The following is a description of a gene set: species: Homo sapiens Autism Autism is a neurodevelopmental disorder characterized by impaired social interaction and communication, and by restricted and repetitive behavior. Autism begins in childhood. It is marked by the presence of markedly abnormal or impaired development in social interaction and communication and a markedly restricted repertoire of activity and interest. Manifestations of the disorder vary greatly depending on the developmental level and chronological age of the individual (DSM-IV). Human Gene Set: HP_AUTISM, and this is the list of marker genes: EEF1A2, DPAGT1, CNKSR2, OCA2, FTCD, TUBG1, BBS1, DPYD, RERE, LIMK1, ATP6V1A, KCNAB2, ANKRD11, WDPCP, SNORD115-1, GABRA2, STS, GABBR2, SUPT16H, DYRK1A, CACNA1A, MAN1B1, EHMT1, BBS9, HESX1, ARL6, DNAJC30, BBIP1, SNORD116-1, CNTNAP2, TAF4, MED12, BUD23, DPYS, BBS4 (Bardet-Biedl syndrome 4), GP1BB, ADNP, ALDH5A1, GABRD, LHX1, TBCK, PWRN1, PDE4D, BBS2, PDPN, RFC2, DNM1, ATRX, HECTD4, SLC13A5, CYFIP2, MAGEL2, EIF4H, OTX2, CEP19, WWOX, NTRK2, GAMT, TTC8, SPEN, ZBTB20, REV3L, GNB1, PTCHD1, EIF4A2, METTL27, SCLT1, GABRA5, ALG14, MKRN3, ATP1A2, AP3B2, KLLN, CYP27A1, NHS (NHS actin remodeling regulator), SEC24C, TAF6, SCN1A, DOCK7, NUS1, ABCB7, NIPA2, SOX3, UFD1, ELN, SETD2, ASXL3, BRD4 (NCBI Gene Id 90616), GTF2IRD1, CHD1, HIRA, HSPG2, MKS1, KDM5C, SATB1, CASZ1, GABRB2, NSUN2, FLCN (NCBI Gene Id 201163), H4C5, SLC9A6, SYNJ1, SEC23B, BAZ1B, PARS2, SDHC, ASCC3, ERI1 (NCBI Gene Id 90459), HERC2, PPP3CA, TAOK1, USF3, DHDDS, SKI, TRAK1, BBS7, PIGL, MED13L, SNRPN, DALRD3, TBL2, NIPA1, MEIS2, SATB2 (NCBI Gene Id 80104), PRKCZ, FTSJ1, FKBP6, CDK13, SMAD4, SYNGAP1, GATM, SMC1A, MECP2, CLIP2 (NCBI Gene Id 84805), RAD21, RREB1, IFT172, RPL10, MMP23B, SDCCAG8, IFT27, MAOA, ARVCF, NSUN6, BBS5, NDN, CACNA2D1, KCNA2, SLC38A3 (solute carrier family 38 member 3), NLGN3, ARNT2, PIK3CA, CREBBP, TBR1, HDAC8, GJA8, FGFR1, AARS1, UBE4B, PIGA, NECAP1, GLRA2, GRIN2D, NIPBL, KCNC2, TSC1, HNF1B, VPS37D, UBE3A, ATP1A3, IQSEC2, CACNA1B, YY1, GABRG2, CFAP418, NR2F1, SCAPER, LUZP1, NAA20, TRIM32 (NCBI Gene Id 3971), NPHP1, SHANK3, NCF1, IFT74, PAK2, HDAC4, LZTFL1, GJA5, SPTBN1, GTF2IRD2, NONO, AHDC1, SCN8A, NPAP1, SLC35C1, DEAF1, RAI1, EXT2, CHD7, CHRNA7, CHD8, GTF2I, PTEN, SIN3A, BBS10, SLC1A2, PACS2, PRDM16, ZFX, SEMA3E, FLG, WFS1, FBXO28, PAH, ADSL (NCBI Gene Id 158), FMR1, HCN1, AKT1, FGF12, KMT2A, TMEM270, ARCN1, GRIA3, TMLHE, PLXND1, SDHD, FZR1, TCF12, CACNA1C, BBS12, SZT2, PROKR2, ALAD, SH2B1, FOXG1, ALG13, SMC3, NAGA (NCBI Gene Id 4668), SCN3A (NCBI Gene Id 6328), TSC2, IL1RAPL1, ACTL6B, NFIB, MKKS, NDP (norrin cystine knot growth factor NDP), STX1A, DICER1, CEP290, SDHB, KCNB1, CLTC, IFNG (interferon gamma), COMT, YWHAG, UBA5, SCN2A, BCKDK, DHCR7, PWAR1, TBX1, CDK19, SOX2, CELF2, EP300, JMJD1C